Given this list of marker genes CYRIB, LZTR1 (leucine zipper like post translational regulator 1), TGM2, FGD1, GIT2, ARRB1, RHOJ, RAP2B, RASA4, MAPKAPK5, CADM4, RAB30, ARF6, DOK7, SOS2, RAPGEFL1, MYO9B, RAB12, FGF2, FARP1, SYNPO2L, MYO9A, NRAS, RAB39B, DOCK6, RALBP1, CHML, PSD2, RAP1B, ARHGAP22, DIRAS3, RAB39A, PKP4, KBTBD7, ARHGEF28 (NCBI Gene Id 64283), ARHGDIA, NUP62, MIR223, ARHGEF15, ARHGAP32, RHOC, AUTS2, SIPA1L1, DAB2IP, RALGPS2, ARHGAP29, OPHN1, KNDC1, RAB9A, PICALM, ARHGAP9, NISCH, MAP2K1, ARHGAP27, RALB, RRAD, ROBO1, FGD5, ARHGAP20, FERMT2, RAB38, BCAR3, ARHGAP1, KRAS, ARHGEF4, COL1A2, IQSEC3, ARHGAP6, RHEBL1, RASIP1, RAB4B, DEF6, CDKN1A, RALGDS, ARHGAP15, PECAM1, DENND4C, VANGL2, ARHGAP35, CUL3, DOCK11, KCTD10, RHOU, RHOH, KSR1, PLD2, DNMBP, SRC, LIMK1, KBTBD6, RHOV, SSX2IP, PLD1, MMD2, RDX, CHN1, ARHGAP8, RASSF1, ARHGEF10L, CGNL1, RHOB, STK19, RUNDC3A, WAS, RHOQ, RASGRP3, DOCK3, RFXANK (regulatory factor X associated ankyrin containing protein), KITLG, ARHGAP18, ALS2, CCDC88C, ABRA, CHN2, RASA3, VAV3, RHOG, MICALL2, ARHGEF9, CFL1, PARK7, GBF1, ADRA2A, MADD, FRMD7, CYTH2, CDC42EP3, USO1, FLOT1, ARHGEF12, PDPN, PLEKHG6, RAB9B, PHACTR4, SYDE2, MYOC, TNFAIP1, ITGAV, FXR1, RAC1, TAGAP, CYTH3, CYTH1, CDK2, ABCA1, ARHGAP19, DENND1A, FGD3, RHOA, IQSEC1, RAB18, ARL3, RAP1GAP2, FARP2, DENND3, GRAP2, NTN1, GPR4, KSR2, RRAGC, F2RL1, ITSN1, ABL1, GMIP, USP50, DNAJA3 (DnaJ heat shock protein family (Hsp40) member A3), CTNNAL1, SYDE1, NRP1, ARFGEF1, SWAP70, RALGAPB, NKIRAS1, RACGAP1, LPAR2, RAB4A, ARHGAP33, PLK2, CDC42SE2, PREX1, SH2D3A, SIPA1L2, PTH, NTRK1, ARHGAP4, FAM13B, SQSTM1, RAB21, ARHGAP40, KANK1, CYFIP1 (cytoplasmic FMR1 interacting protein 1), MIR21, ITGB1, RABGEF1, SHTN1, RASGEF1A, RGS19, RGL2, ARHGDIG, RAPGEF4, LRRK2, RHOBTB2, DOCK1, GPR55, ARHGEF40, ARHGAP12, ARAP1, RRAS, ABR, RERG, GARNL3, CHP1, MFN2, ARHGAP44, RASGRP4, PLEKHG7, FGD4, APOC3, CDH13, FGD2, ARHGAP11A, MIR29B1, MCF2L (MCF.2 cell line derived transforming sequence like), RABL3 (NCBI Gene Id 285282), RND3, RASGEF1B, TNK2, APOA1, DOK2, TSC2, RABIF, AIF1, CBL, PSD4, SH3BP1, PLCD4, FNTA, CDC42EP2, RND2 (NCBI Gene Id 8153), NGEF, SPRY4, CXCL13, SIAH2, PLEKHG4B, ARFGEF3, DOCK4 (dedicator of cytokinesis 4), LRP4, GNA13, ARHGAP5, ARHGAP21, GDI1, SOS1, KCTD13, CSNK1A1, DBNL, RAP2C, NOTCH1, CDC42EP4, ARHGEF19, ABL2, RALGPS1, ABI2 (abl interactor 2), ARHGEF3, ELMO1 (engulfment and cell motility 1), RAB35, RASAL3, SIPA1 (NCBI Gene Id 6494), CCL19, RHOBTB1, AMOT, LPAR1, NKIRAS2, RGL1, SRGAP2, PSD3, RAB15, RAB6C, F2R, DLC1, LAT, CDC42EP1, ARFGEF2, RHEB, RND1 (Rho family GTPase 1), CELSR1, RAPGEF6, ARHGEF16, ITPKB, RAB33A (NCBI Gene Id 9363), ARHGEF2, VAV1, DOCK2, MAPKAP1, PSD, TNS3, GNA12, RAPGEF3, CDON, CDKL5, ARHGEF5, HRAS, CSF1, ARHGAP11B, EPS8L3, SPRY3, DOCK9, BRAP, RAF1, C15orf62, ARHGAP26, ARHGAP23, PIK3CG, PLEKHG3 (pleckstrin homology and RhoGEF domain containing G3), SPRY1, ARHGEF18, GNB1, DOK3, GDI2, TRIM67, COL3A1, RGL4, RHOF (NCBI Gene Id 54509), ADGRG1, RASL10A, OGT, RHOD, G3BP1, ARHGAP30, EPS8L1, ARHGAP24, RASGRF2, ARHGAP25, SCAI, PLEKHG5, STARD8, IQSEC2, LIPA, SYNJ2BP, PLEKHG4, TIAM1, VAV2, BCR, RASA4B, RUFY1, CRK, PIN1, RAPGEF5 (NCBI Gene Id 9771), BNIP2, STMN3, ARHGEF7, ERBB2, RIN2, DOCK8, RAP1A, BRK1 (BRICK1 subunit of SCAR/WAVE actin nucleating complex), CYTH4, ADCYAP1R1, RRAS2 (RAS related 2), PLCE1, SYNGAP1, EPS8L2, ARHGAP28, HACE1, DENND4A, FLCN, CRKL, ARHGEF17, RASGEF1C, WASF2, FBP1, RELN, RTN4, CCR7, SPRY2, RAB33B, RGL3, SHOC2, RIPOR2, RASGRP1, IQGAP3, RTKN, DOCK10, EPO, NGFR, SLIT2, ARHGAP39, DOCK7, ARFGAP1, CDC42, CCNA2, NOTCH2, STMN1, TP53, ARHGAP31, YWHAQ, WNK1, CHM, AGTR1, STARD13, RAC3 (NCBI Gene Id 5881), AKAP13, RASGRF1, DOK1, TEK, DHCR24, PPP2CB, RAC2, SIPA1L3, KIF14, NUCB1, SPATA13, NF1, SRGAP1 (NCBI Gene Id 57522), CDKN2A, PRAG1, IGF1, MAPRE2, TAX1BP3, RTN4R, EPS8, RAP1BL, RALGAPA1, FOXM1, APOE, SRGAP3, SDCBP, DOCK5, FAM13A, PDCD10, RIPOR1, SH2D3C, STAMBP, GRB2, MCF2, ARHGAP17, NUCB2, USP8, ARHGEF25, ARHGAP45, TRIO, NCKAP1, RAP2A, SEMA4D, ROCK2, CCDC125 (coiled-coil domain containing 125), MAP4K4, CCDC88A, KANK2, ROPN1B, ARHGEF10, RAPGEF1, PREX2 (phosphatidylinositol-3,4,5-trisphosphate dependent Rac exchange factor 2), RIT2, KRIT1, NET1, GRAP, ARFIP2, HACD3, ARHGDIB, WASF1, ECT2, KALRN, RALGAPA2, ARHGAP10, ERAS, RAP1GAP, TIAM2 (TIAM Rac1 associated GEF 2), RALA, SGSM3, FBXO8, CD2AP, MET, RB1, GARRE1, DENND4B, PLEKHG1, NGF, RAPGEF2, GIT1, BCL6, CDC42EP5, RASAL1, FGF10, ARHGEF11, EPHB2, CDC42SE1, GABARAP, PIK3CB, ARHGAP42, ARHGEF1, DAB1, PLXNB1, F11R, RIT1, HEG1, RASGRP2, OBSCN, RASA2, TGFB2, ROCK1, MRAS, ITGA3, here is a description of the gene set: An intracellular signaling cassette in which a small monomeric GTPase relays a signal. Human Gene Set: GOBP_SMALL_GTPASE_MEDIATED_SIGNAL_TRANSDUCTION studied in species Homo sapiens